The following is a description of a gene set: Human Gene Set: GOBP_LYMPH_NODE_DEVELOPMENT species: Homo sapiens The process whose specific outcome is the progression of lymph nodes over time, from their formation to the mature structure. A lymph node is a round, oval, or bean shaped structure localized in clusters along the lymphatic vessels, with a distinct internal structure including specialized vasculature and B- and T-zones for the activation of lymphocytes., and this is the list of marker genes: CXCR5, RCBTB2, FADD, TRAF3IP2, LTB, RORC, IL15, NKX2-3, CD248, RC3H1, IL7R, TNFRSF11A, PDPN, RC3H2, POLB, LTA, SPNS2, CD2AP, TGFB1 (transforming growth factor beta 1), RIPK3, TOX